The following is a description of a gene set: Mouse Gene Set: GOBP_DEDIFFERENTIATION studied in species Mus musculus The process in which a specialized structure (cell, tissue or organ) loses structural or functional features that characterize it in the mature organism, or some other relatively stable phase of the organism's life history. Under certain conditions, these structures can revert back to the features of their ancestors., and this is the list of marker genes: Cdk6, Nanog, Pdgfb, Ncoa3, Esrrb, Hnrnpd, Fezf2, Olfm2, Fezf1